Given this list of marker genes F2RL3, SRC, PROSER2, GP9, ANOS2P, TMEM91, WFDC1, H2AC6, NOS1AP, MPL, MPIG6B, ELOVL7, PDE5A, NBEAL2, INHBA-AS1, ADCY6 (adenylate cyclase 6), MYO18B, GNB5, SNAI3-AS1, PLCB4, NME9, HPSE, ITGB3, ITGA2B, LINC02770, EFCAB13-DT, PLEK, SLC37A1, LTBP1, XYLT2, RPS12P16, EGR3, DYNC1I1, RAP1B, FXYD5, GP6, TTC39B, LIPH, MDM1, RAB37, ASAP2, DENND2C, LY6G6F, TREML1 (triggering receptor expressed on myeloid cells like 1), CFAP45, PTCRA, PF4, DGKG, PRKAR2B, CATSPER2P1, SLC2A3, COL24A1, LGALSL, RASA3, PRKAR2B-AS1, ELAPOR2, GP1BA, THBS1, RAB3C, RBPMS2, LGALSL-DT, CDC14B, ING5, CLEC1B, MPP7, RADIL, DNMT3B (DNA methyltransferase 3 beta), ACTN1, LINC00989, LANCL3, RUFY1, LINC00504, MCF2L, MFAP3L, ZNF691, ENSG00000230773, NEXN-AS1, IRAG1, CNST, MYO3B, LINC02284, LINC02951, SELP (selectin P), EFHC2, LAT, RSU1 (Ras suppressor protein 1), USH2A, C2orf88, SLC9A1, EGF, VCL, ALOX12, NINJ2-AS1, F13A1, TMEM40, HTR2A, MED12L, IRS2, MYOM1, RAB27B, XIRP2, NEXN (nexilin F-actin binding protein), GABRE, LINC00299, RGS18, NLK, KIAA0513, PPBP, KBTBD12, DNM3, APPBP2-DT, GNAZ, MMRN1, CD226, here is a description of the gene set: Human Gene Set: DESCARTES_FETAL_SPLEEN_MEGAKARYOCYTES species: Homo sapiens Marker genes curated from the annotated cluster as represented in the Descartes Human Gene Expression During Development database. The gene expression program underlying the specification of human cell types is of fundamental interest. The study authors generated human cell atlases of gene expression and chromatin accessibility in fetal tissues. For gene expression, the study authors applied three-level combinatorial indexing to >110 samples representing 15 organs, ultimately profiling ~4 million single cells. The study authors leveraged the literature and other atlases to identify and annotate hundreds of cell types and subtypes, both within and across tissues. Our analyses focused on organ-specific specializations of broadly distributed cell types (such as blood, endothelial, and epithelial), sites of fetal erythropoiesis (which notably included the adrenal gland), and integration with mouse developmental atlases (such as conserved specification of blood cells). These data represent a rich resource for the exploration of in vivo human gene expression in diverse tissues and cell types. from publication Cao J, O'Day DR, Pliner HA, Kingsley PD, Deng M, Daza RM, Zager MA, Aldinger KA, Blecher-Gonen R, Zhang F, Spielmann M, Palis J, Doherty D, Steemers FJ, Glass IA, Trapnell C, Shendure J (PMID 33184181)